Given this list of marker genes TGFBR2, EFEMP2 (EGF containing fibulin extracellular matrix protein 2, NCBI Gene Id 30008), TGFBR1, IPO8, POLR1A, COL3A1, COL5A1, BGN, here is a description of the gene set: species: Homo sapiens Human Gene Set: HP_PULMONARY_ARTERY_ANEURYSM Pulmonary artery aneurysm An aneurysm (severe localized balloon-like outward bulging) in the pulmonary artery.